Given this list of marker genes Gmnn, Ticrr, Ciz1, Kat7, Cdt1, Wrnip1, Mcidas (NCBI Gene Id 632552, multiciliate differentiation and DNA synthesis associated cell cycle protein), Gmnc, Cdk2, here is a description of the gene set: Mouse Gene Set: GOBP_REGULATION_OF_DNA_TEMPLATED_DNA_REPLICATION_INITIATION Any process that modulates the frequency, rate or extent of initiation of DNA-dependent DNA replication; the process in which DNA becomes competent to replicate. In eukaryotes, replication competence is established in early G1 and lost during the ensuing S phase. studied in species Mus musculus